The following is a description of a gene set: Genes positively differentially expressed in cell type: CD4+ T cell upon treatment with cytokine: IL-15 in mouse lymph nodes in vivo. species: Mus musculus from publication Cui A, Huang T, Li S, Ma A, Pérez JL, Sander C, Keskin DB, Wu CJ, Fraenkel E, Hacohen N (PMID 38057668) Mouse Gene Set: CUI_T_CELL_CD4_IL15_RESPONSE_UP Cytokines mediate cell-cell communication in the immune system and represent important therapeutic targets. A myriad of studies have highlighted their central role in immune function, yet we lack a global view of the cellular responses of each immune cell type to each cytokine. To address this gap, the authors created the Immune Dictionary, a compendium of single-cell transcriptomic profiles of more than 17 immune cell types in response to each of 86 cytokines (>1,400 cytokine-cell type combinations) in mouse lymph nodes in vivo. A cytokine-centric view of the dictionary revealed that most cytokines induce highly cell-type-specific responses. For example, the inflammatory cytokine interleukin-1β induces distinct gene programmes in almost every cell type. A cell-type-centric view of the dictionary identified more than 66 cytokine-driven cellular polarization states across immune cell types, including previously uncharacterized states such as an interleukin-18-induced polyfunctional natural killer cell state., and this is the list of marker genes: Apobec3, Gbp7, Psmb9, H2-T23 (histocompatibility 2, T region locus 23), Ddx24, Samd9l (NCBI Gene Id 209086), Ifi203, Oas3, H2-T22, Irf1, Oasl2, Zup1, Ly6e, Mndal, Psma2, Socs1, Trim12c (NCBI Gene Id 319236), Gbp9, Xaf1, Stat3, Psmb10, Icam1, Bcl3, Gbp4, Psmb8, Daxx, Irgm2, Ifi209, Casp8, Isg20, Ifi35, Mthfd2, Rigi, Ndrg3, Parp9, Igtp (interferon gamma induced GTPase), Trim25, Rnf114, Gbp5, Chmp4b, Gbp8, Ifit1, Sting1, Irf7, Ifit3, Trim30a, Eeig1, Eif5a, Dtx3l, Pml, Parp14, Calhm6, Nmi, Psme1, Rtp4, Notch1, Iigp1, Eif2ak2, Ccnd2, Ifi27l2a, Psma7, Usp18, Psme2, Zbp1, Ppa1, Ly6c1, Igfbp4, Cd274, Bst2, Ifi206, Clic4, Arid5b, Phf11c, Rapgef6, Tap1, Cdkn2d (cyclin dependent kinase inhibitor 2D), Phf11b, Isg15, Ifi208, Bcl2, Gbp6, Gbp2, Helz2, Slfn8, Tgtp1, Slfn2, Ms4a4b, Irf8, Eif2s2, Samhd1, Epsti1, Socs3, Nampt, Slfn1, Rnf213, Trim56, Ifi214, Tgtp2, Ly6a, Tapbpl, Ddx60, Lgals3bp, Irgm1, Tapbp, Treml2, Nlrc5, Trim12a, Pim1, Sbno2, Slfn5, Ifi213, Stat2, Ifi47, Gimap4, Pgs1, Mitd1, Stat1, Irf9